Given this list of marker genes Mad2l2, Flrt2, Pfn2, Stub1, Hip1r, Phldb1, Nav3, Il1rap, Tpr, Cbln1, Entr1, Isg15, Epha2, Stmp1, Lmod2, Cdh17, Ccdc88a, Nck1, Cd24a, Fermt2 (NCBI Gene Id 218952), Kit, Synpo, Dhx33, Nrg1, Rp1, Cdc42ep4, Cracd, Ptk2b, Lrrtm1, Hopx, Ccl21a (C-C motif chemokine ligand 21 (serine)), Btk, Pfn1, Enpp2, Iqgap1, Musk, Tlr6, Sdcbp, Agrn, S100a10, Prkcq, Atg5, Swap70, Dync1h1, Dlg1, Hdac4, Brcc3, Saxo1, Ccl11, Moap1, Mavs, Hsf1, Plcg2, Tpm1, Myoc, Tapt1, Chga, Atat1, Ulk1 (NCBI Gene Id 22241), Numa1, Gbp2, Ambra1, Nckap1l, Adgrb3, Ppm1f, Tpbg, Sema4a, Cldn3, Nckap1, Pde4dip, Tac1, Dock11, Twf2, Aqp1 (NCBI Gene Id 11826), Arhgef15, Epn1, Slain2, Abca3, Nox4, Thbs2, Mmp1b, Syk, Rhoq, Cdc42ep3, Skap1, Kiss1r, Cdc34, Ppp2ca, Psmc6, Cnot6l, Ptpn11, Dnm2, Ppp1r35, Map3k1, Ccl21e, Rap1b, Fchsd1, Adgrb1, Cxcl13, Clu, Fmn1, Slit2, Becn1, Pip4k2a, Neurl1a, Ralb, Tnf, Bax, Mapk8, Sdc4, Atg2a, Psmc5, Tek, Sox9, Plek2, Ace2, Vasp, Wipi1, Vstm5, Agt, Ccl21b, Nlgn2, Ice1, Rhoc (ras homolog family member C), Cenpj, Il17a, Map4k4, Baiap2l1 (BAI1-associated protein 2-like 1), G3bp2, Cep120, Brk1, Actr3, Ripor2, Tsg101, Tesk1, Tacr1, Wars1, Usp16, Snx9, Snx7, Mpp7, Ift20, Atm, Iqsec2, Evl, Ntrk2, Sorbs3, Akirin1, Tlr4, Srpx2, Thy1, Bdnf, Clstn3, Sdc1, Caly, Sumo1, Map1b, Slf1, Ephb3, Snx30, Lrrtm2, Fas, Brcc3dc, Kdr, Hrg (histidine-rich glycoprotein), Ndel1, Nphs1, Cldn1, Spag5, Faf1, Plce1, Flrt1, Poc1b (POC1 centriolar protein B), Hspa1a, Adgrl2, Arhgef5, Icam1, Epha1, Hras, Atr, Slx1b, Bmp7 (bone morphogenetic protein 7), St8sia2, Msn, Mapk15, Cdc42ep5 (CDC42 effector protein 5), P2ry12 (NCBI Gene Id 73058), Dlg4, Lrrn1, Gda, Eps8, Cldn5, Mapt, Slain1, Lgals3, Lmod1, Myh9, Avil (NCBI Gene Id 11567), Amigo3, Rab7, Cnot6, Med25, Csf2, Tmem67, Wnt11, Ephb2, Auts2, Cdkn1b, Cttn, Rala, Apoa1, Abca1, Bik, Def8, Arl2, Plppr5 (NCBI Gene Id 75769), Septin9, Gsk3b (glycogen synthase kinase 3 beta), Pik3r1, Pdcd6ip, Bbc3, Eps8l3, Sass6, Atp7a, Rab3gap1, Myd88, Has3, Apoe, Stx18, Zmynd10, Pycard, Ntrk3, Piezo1, Nup62, Mien1, Ccn2, Trim65, Caprin1, Snf8, Oxtr, Il5 (interleukin 5), Atp13a2, Fhod1, Git1, Rapgef3, Cx3cl1, Wnt7a, Adgrl1, Nek7, Arap1, Ttbk2, Plek, Fmr1, Fnip1, Vegfa, Cand1, Lingo2, Csf3, Tal1, Ptprj, Ccr7, Casp4, Pfn3, Nr1h2, Pfn5, Snca (NCBI Gene Id 20617), Mark4, Fuz, Fnbp1l, Mecp2, Rock1, Grb2, Clstn1, Fchsd2, Cdc42, Ube2v2, Actr2, Pan2, Ccl24 (C-C motif chemokine ligand 24), Foxc2, Adgrb2, Mtss1, Dsg3, Myo3b, Emilin1, Ptpn22, Dynll1, Snap91, Rock2, Grid2, Vps4b, Sh3glb1, Ldb2, G3bp1, Oxt (NCBI Gene Id 18429), Epb41l5, Itgb1bp1, Srf, Fes, Ptprd, Bak1, Hrk, Gnl3l, Apc, Ifng, Src, Ccl21d, Pdlim4, Tsc1, Prkd1, Efna5, Poldip2, Prkca, Clec7a, Cbln2, Frmd7, Snx18, Slf2, Smad3, Pcsk5, Vps4a, Ttbk1, Spidr, Nox1, Stau2, Lats2, Lingo4, Braf, Stil, Flna, Lpar1, Slitrk5 (NCBI Gene Id 75409), Gm12250, Slitrk2, Lrsam1, Psrc1, Phldb2, Cck, Hdac6, Iqsec1, Tenm1, Abi2, Arhgef10, Arpc2, Akap9 (NCBI Gene Id 97235), Ntrk1, Cdk5rap2, Rhoa, Il1rapl1, Wnt10b, Lrrc4b, Ccl19, Synpo2, Syndig1, Bid, Mmp3, Eef2k, Flrt3, Zmynd8, Tgfb1, Espn, Fnip2, Limch1, Adgrl4, Hsp90aa1, Rac1 (NCBI Gene Id 52352), Mtor, Slx4, Rictor, Ccdc15, Tbx5, Rps3, Cdc34b, Bmf, Eif4g1, Park7, Clip1, Tirap (NCBI Gene Id 117149), Hyal1, Ppm1e, Adgrl3, Clasp1, Cdh5, Ahr, Xlr3b, Arf6, Bag4, Fermt1, Lats1, Slitrk4, Lcp1, Unc13b, Cd47, Rasip1, Nlgn1, Pip4k2c, Wnt1, Kirrel1, Vil1, Stam, Cep135, Col16a1, Fam98a, Ckap5, Smad4, Nck2, Dctn1, Dzip1, Sh3pxd2b, Arhgef10l, Wasl, Wnt4, Htt, Ccl21f, Cep295, Carmil1, Plekhm1, Rab3ip, Tppp2, Trhr, Togaram1, Id1, Fscn1, Carmil2, Amigo2, Lrtm2, Drg1, Alox15, Pxn, Nphp1, Crb3, Rac2, Gpm6a, Amigo1, Ccp110, Mmp1a, Terf1, Rims1, Lrrtm4, Fer, Rgcc, Myo1c, Mapre1, Ift88, Plk4, Tppp3, Clasp2, Dag1, Clrn1 (clarin 1), Nlgn3, Dlg5, Zdhhc5, Tgfb3, Pan3, Crocc, Limk1 (NCBI Gene Id 547389), Mlst8, Ppp2r5b, Bin1, Chmp2a, Cav3, Cldn19, Dnm3, Dpysl3, Mstn, Cdk2, Pak1, Nphp4, Adnp, Usp50, Hap1, Snx4, Baiap2, Cnot2 (NCBI Gene Id 97648), Tppp, Ccl26, Myo5b, Kctd17, Nrxn1, Cdc42ep1, Ankrd53, Bbs4, Cux2, Bcl2l11, Synpo2l (synaptopodin 2-like), P2rx7, Hspa1b, Wrap73, Flot1, Atmin, Serpinf2, Ajuba (ajuba LIM protein), Mtln, Ikzf1, Crbn, Smpd3, Wasf2, Ercc1 (excision repair cross-complementing rodent repair deficiency, complementation group 1), Met, Gpr65, Hgs, Zdhhc1, Lims1, Cnot1, Rack1, Slitrk1, Dab2ip, Acvrl1, Elapor1, Arhgap35, Cdc42ep2, Ghrl, Asic2, Tenm2, Slitrk6, Lrtm1, Irx3, Hif1a, Lrrtm3, Vcp, Nf2, Creb1, Cav1, Ephb1, Rab11fip3, Anln, Tfrc, Ubap2l, Trabd2b, Adgre5, Gdf2, Myo3a, Trim32, Cobl, Cntnap2, Prkce, Sema4d, Nrp1, Rab3gap2, Lrrn3, Mapk9, Ddx3x, Cfl1, Gpsm2, Abl1, Wdr45, Cyfip1, Pqbp1, Mns1, Eps8l1, Baiap2l2, Gbp5, Tgfbr1, Lrrc24, Gm14137, Pip4k2b, Clstn2, Bhlhb9, Trp53, Eps8l2, Slitrk3, Palm, F2rl1, Cd36 (CD36 molecule), here is a description of the gene set: studied in species Mus musculus Any process that activates or increases the frequency, rate or extent of cellular component biogenesis, a process that results in the biosynthesis of constituent macromolecules, assembly, and arrangement of constituent parts of a cellular component. Mouse Gene Set: GOBP_POSITIVE_REGULATION_OF_CELLULAR_COMPONENT_BIOGENESIS